The following is a description of a gene set: Genes containing one or more binding sites for (NR4A2) in their promoter regions (TSS -1000,+100 bp) as identified by GTRD version 20.06 ChIP-seq harmonization. Human Gene Set: NR4A2_TARGET_GENES species: Homo sapiens from publication Yevshin I, Sharipov R, Kolmykov S, Kondrakhin Y, Kolpakov F (PMID 30445619), and this is the list of marker genes: LINC02564, PCGF3 (NCBI Gene Id 253443), SNX8, EIF3B, KMT2A